Given this list of marker genes H2-Q7, Tap1, H2-T22, H2-M10.4, H2-K1, H2-M10.2, H2-Q1, H2-Q2, Tap2, H2-Q10, H2-Q6, H2-M11, H2-M10.1, H2-M2, Tapbp, H2-D1, H2-M10.6, H2-M5, here is a description of the gene set: species: Mus musculus Binding to the TAP1 subunit of TAP (transporter associated with antigen processing) protein. Mouse Gene Set: GOMF_TAP1_BINDING